The following is a description of a gene set: Any process that modulates the frequency, rate or extent of the chemical reactions and pathways involving nucleotides. Human Gene Set: GOBP_REGULATION_OF_NUCLEOTIDE_METABOLIC_PROCESS species: Homo sapiens, and this is the list of marker genes: ATPSCKMT, TAFAZZIN, ACMSD, NCOR1, FLCN, GUCA1A, FIS1, ADCY10, PRKAA2, PRKAG3, APP, TIGAR, JMJD8, STAT3, ARL2, TRIM63, TREM2, FBP1, GPD1, SRC, HDAC4 (histone deacetylase 4), PPARA, ZBTB7A, HIF1A, SLC4A4, TSPO, IL4, IER3, VCP, ATP5IF1, PINK1, PRKAA1, BEND3, MAP2K1, PSEN1, KAT2B, PRKAG2, IGF1, ME2, HTR2A, DNAJC30, OGT, NDUFC2, SLC4A1, DDIT4, TMSB4X, PRKACA, UCHL1, IFNG, RD3, MTCH2, SIRT6, ANTKMT (NCBI Gene Id 82377), PPP2CA, PFKFB1, INS, PID1, TP53, PRKN, CDA, INSR, DNM1L, PRKAG1, ME1, RPTOR, SPHK2, ENO1, SLC2A6, MLST8, P2RX7, ALDOB (aldolase, fructose-bisphosphate B), PRXL2C, MTOR, PARP1, EIF6, GCK, CBFA2T3, ZBTB20, LACC1, EP300, ARNT, MACROH2A1, GAPDHS, ACTN3, GUCA1ANB-GUCA1A, GIT1, MIR675, TREX1, MLXIPL, NUPR1